Given this list of marker genes AGXT2, NT5C3A, DPYD, NT5C1A, DPYS (NCBI Gene Id 1807), NT5M, TYMP, NT5C, UPP1, UPP2, NT5E, UPB1, here is a description of the gene set: part of: Nucleotide catabolism In parallel sequences of three reactions each, thymine is converted to beta-aminoisobutyrate and uracil is converted to beta-alanine. Both of these molecules are excreted in human urine and appear to be normal end products of pyrimidine catabolism. Mitochondrial AGXT2, however, can also catalyze the transamination of both molecules with pyruvate, yielding 2-oxoacids that can be metabolized further by reactions of branched-chain amino acid and short-chain fatty acid catabolism. The importance of these reactions in normal human pyrimidine catabolism has not been well worked out. studied in species Homo sapiens Reactome Pathway: Pyrimidine catabolism